Given this list of marker genes Cib1, Akirin2, Mvd, H2ac13, Foxj2, Clec7a, Ifit3, Ifitm1, Map2k5, Rbbp9, Ern1, Bcl7a, Lilrb4a, Zp3, Tfap2e, Cd59b, Wnt2, Bcl2, Kifap3, Trpc5, Ambn, Has2, Bnipl, Nodal, Hif1a, Hsf1, Glmn, Inppl1, Fgf1, Ptpn22, Usp17le, Fbxw4, Abl1, Fxn, Dlx6, Cdk6, Tjp1, Ifi35, Pbxip1, Pla2g4a, Gata1, Eef1e1, Sult2b1, Pdgfrb, Setd1a, Prkd1 (NCBI Gene Id 18760), Trf, AY074887, Tmigd1, Sgpp2, Irak4 (NCBI Gene Id 77562), Kdf1, Foxa3 (NCBI Gene Id 15377), Pdpk1, Prkd2, Raf1, Ptprz1 (protein tyrosine phosphatase receptor type Z, polypeptide 1), Tfap2b, Azin1, Btla, Niban2, Zfp143, Zc3h12d, Dgcr8, Ceacam1, Irs2, Trpv2, Irgm1, Ripor2, Errfi1, Wdr62, Vav3, H2-M3, Dmd, Hmga2, Pdcd5-ps, Jund, Itga2, Il20rb, Grk5, Ptgdr2 (prostaglandin D2 receptor 2), Por, Cd109, Smad7, Eps15, Krt4, Reg2, Sts, Grk2, Atxn1, Sparc, Flt4, Acer2, Abcc8, S100a13, Sftpd, Scin, Avp, Sox18, P2ry6, Gata3, Dach1, Arhgap5, Aqp11, Septin4, Ptprn, Smarcb1, Dlc1, Junb, Itga1, Calcrl, Icosl, Celf1, Hdac5, Il1rl1, Nf2, Crlf1, Edn2, Rest, Areg, Irak1, Prl, Prdm1, Syk, Adm, Pim1, Fezf1, Nlrc3, Ogn, Fbrs, Braf, Cdkn2c, Rps6kb1, Vtcn1, Cthrc1, P3h3, Ppp1r15a, Camk2d, Rida, Foxg1, Emp2, Pramel7, Cep131, Slurp1, Smad2, Tns3, Col18a1, Gna12 (NCBI Gene Id 14673), Smo, Setd4, Ing4, Prrx2, Wnt7a, Taf6, Cxcr2, Ace (angiotensin I converting enzyme), Fermt2, Cblb, Sdcbp, Agbl4, Nudt6, St6gal1, Cdkn1b, Iqgap3, Adora3, Jun, Fntb, Lama5, Tfdp1, Lims2, Cxcr3, Ccdc117, Smarcd3, Meis3, Gab2, Smad3, Zfp580, Egf, Nupr2, Arrb2, Mta3, Myog, Ifit3b, Akt1, Optn (optineurin), Gnai2, Tnfsf9 (tumor necrosis factor (ligand) superfamily, member 9), A4gnt, Ctf2, Aif1, Pkhd1, Trim24, Rab25, Bricd5, Kctd11, Tgfb1, Cd46, Cdc6, Pdcd4, Il3, Il11ra2, Atoh8, Sulf2, Adam17, Chp2, Sfrp4, Ppp2r3d, Ccne1, Ifnb1, Znhit1, Cldn3, Akr1b1, Cfdp1, Agtr1b, Comt, Ddx39b, Pik3ca, Cela1, Lyn, Tarm1, Vegfc, Osr1, Cdca7l (NCBI Gene Id 217946), Nme2, Hyal1, Erbb3, Gnrhr, Mapk14, Ccn2, Fgf6, Wfdc1, Bmpr2, S1pr1, Wnk2, Gas1, Esr1, Wwtr1, Scrib, Il33, Il31ra, Prkar1a, Tnf, Phox2b, Spn, Ccna2, Cacul1, Zfp503, Pds5b, Fto, Npr3, Ccnd1, Zbtb17, Cdkn2b, E2f4, Tmem119, Fzd3, Vsx2, Pou1f1, Lin28a, Rspo1, Emc10, Zfp36l1 (zinc finger protein 36, C3H type-like 1), Rassf5, Dkc1, B4galt7, Ahr, Klf4, Eng, Prrx1, Tsc22d1, Pmaip1, Adcyap1, Tial1, Rsu1, Kcnk2, Pax6, Dot1l, Foxj1, Vsig4, Carmil2, Riox2 (NCBI Gene Id 78649), Pten, Marcksl1, Rassf10, Drd4, Orc1, Bcar3, Tpd52, Rprd1b, Srf, Nkx2-5, Apobec1, Egfr, Nr2f2, Id4, Hoxd13, Rnf139, Foxp3, Adam33, Nap1l1, Dsc1, Gli3, Topors, Dmrta2, Pde5a, Mapk8, Blm, Ifng, Hnf4a, Bmp7, Dspp, Klf11, Xrcc6, Vax1, Fezf2, H19, Ptn, Txnl4b, Sfrp1, Myo16, Serpine1, Mir145a, Dvl2, Ccn5, Pla2g2a, Trim71, Fut2, Six4, Ada, Adam10, Zbtb7b, Reg1, Tbx18, Ntrk3, Hpgd, Klf5, Vsir, Nr3c2, Ptpn2, Nme1, Igfbp3, Trappc14, Med31, Fut1, Htra1, Hlx, Gdf9, Inha, Tnfrsf1b, Fndc3b, Cd44, Dbh, Bmi1, Ptgir, Fasl, Mir133a-1, Cdk1, Bmyc, B4galt1, Fgf17, Anp32b, Igf1r, Rc3h1, Fmc1, Ago3, Uts2r, Ecm1, Map3k5, Cd37, Tbx3, Adk, Grn, Plcd1, Zeb1, Actl6a, Fbln1, Akirin1, Timp1, Kitl, Il2, Pde1a, Spint2, Hmgn5, Sbno1, Nr5a2, Ifna11, Maged1, Pmp22, Cul4a, Nupr1, Atg101, Taf4b, Stat4, Osmr, Hspa1a, Tbrg1, Il7r, Gas6, Il4i1, Vegfa, Atg13, Cyp1b1, Prl2c3, Gpc3, Lrrc32, Nfkbia, Cst3, Smarca1, N4bp2l2, Tac1, Lta, Fermt1, Fer, Slit2, Tyk2, Nkx3-1, Rps4x, Npm1, Cebpb, Rxfp2, Notch2, Cdc7, Gstp1, Osm, Hrh3, Ufl1, Hilpda, Cd209e, Ptpn1, Gdf5, Ghsr, Nfatc2, Lrrk2, Ftmt, Fas, Prkci, Rbm38, Zmiz1, Sox11, Tgfb3, Zfp335, Cnn2, Il1b, Creb1, Pkn1, Sirt1, Gna13, Prc1, Gid8, Gfap, Pkd2, Havcr2, Wdr13, Zfp703, Skap2, Tal1, Sos2, Klf9 (NCBI Gene Id 70273), Siglecg, Zbtb49, Megf10, Rasa1, Tesl1, Notch1, Cherp, Anxa2, Mapk1, Mdm4, Il10, Hmox1, Ndrg4, Pdgfd, Il21, Rgn, Cdon, Pbrm1, Fn1, Rps6ka2, Ndfip1, Adora1, Fanca, Nos3, Thrb, Cd244a, Ift80, Tmem127, Eif2ak1, Mir223, Fgf22, Trnp1, Ndufaf4, Pax3, Src, Pde4d, Btn2a2, Cnot6l, Ripply3, Neu1, Rasip1, Hmx2, Lef1, Il1a, Nck2, Fgf3, Drd2, Mir133a-2, Dnaja3, Tgfb2, Gja1, Marchf7 (membrane associated ring-CH-type finger 7), Sp1, Ski, Ier5, Esrp2, Chrd, Cd209c, Strn, Msx2, Sh3bp4, Hras, Nmbr, Mad1l1, Gpnmb, Mup20, Akr1c18, Eaf2, Rxra, Dhcr24, Wwc2, Dusp10, Pttg1, Slfn3, Bmp2, Ido1, Garem1, Ngfr, Odc1, Casp3, Fbln5 (NCBI Gene Id 23876), Ccl12, Il12rb1, Romo1, Avpr1b, Kank2, Cd209d, Zap70, Mks1, Traf5, Adarb1, Amelx, Ldlrap1, Nck1, Tnc, Intu, Pggt1b, Klb, Spdya, Sphk1, Tfap4, Il6, Sdc4, Sema5a, Mef2d, Avpr2 (NCBI Gene Id 12000), Klhl41, Gata6, Foxf1, Wdr6, Cd40lg, Pold4, Il12rb2, Wnt1, Vegfd, Cd22, Magi2, Krit1, Chst11, Gnas, Fosl2, Kiss1, Pdcd2, Ccn6, Laptm5, Gper1, Ihh, Tirap, Zbtb16, Skp2, Tesc, Ptk2b, Il5, Osgin1, Ndrg1, Cend1, Ccn3, Nolc1, Pdgfc, Itgal, Wdr48, Trp53inp1, Il2ra, Tnfrsf21, Ctla4, Jag1, Gucy2c, Becn1, Kit, Mir219a-2 (microRNA 219a-2), Reg3a, Gdf2, Kdm2b, Phf7, Tead1, Nos1, Glul, Ticam1, Ezh2, Sh2b3, Ss18, Pth1r, Peli1, Crtam, Fgf15, Clcf1, Rictor, Mstn (NCBI Gene Id 17700), Muc16, Sox2, Nog, Fgfr1, Six5, Insr, Tgm2, Il6ra, Marveld3, Ptprm, Aldh3a1, Tnfsf4, Csk, Shc1, Fgf21, Tfap2d (NCBI Gene Id 226896), Sf1, Pitx3, Slc7a5, Pin1, Ksr1, Vcam1, Cd1d2, Axin2 (NCBI Gene Id 12006), Grpr, Cer1, Ednrb, Acvrl1, Emilin1, Slc4a1, Six1, Kcnh1, Sinhcaf, Plag1, Bmpr1a, Prdx3, Gal, Cripto, Rtn4, Mir574 (microRNA 574), Lgmn, Gpr183, Jak3, Dhps, Shoc2, Gak, Ins1, Bst1, Smarcd1, Fzd9, Bex1, Chek1, Shcbp1, Trim32, Kif20b, C3ar1, Cnot8, Crh, Dpp4, Eppk1, Cd59a, Ang6, Pdcd5, Vash2, Gpld1, Il4, Isl1, Ngf, Cyp7b1, Mir205, Rasgrf1, Fadd, Snhg15, Ikzf3, Hmga1b, Smad6, Efnb1, Gata4, Sox10, Cd55, Dnajb2, Cnn1, Atp5if1, Pdgfb, Etv5, Kmt2a, Comp, Coro1a (NCBI Gene Id 16902), Ang, Mab21l2, Fxyd2, Chrnb2, Srpx, Pycard, Dis3l2, Oog1 (NCBI Gene Id 193322), Fes, Xcl1, Prkaca, Cdk2 (NCBI Gene Id 353061), Il12b, Pou3f2, Phlda2, Cops9, Mst1, Igfbp5, Ptprc, Ctnnb1, Slc25a27, Jcad, Slc16a2, Nox4, Dnmt1, Pth, Bmp4, Bicra, Map2k1, Flcn, Ppargc1a, Hes5, Tbx2, Enpp3, Pf4, Fnip1, Nampt, Ptgis, Cep43, Gkn3, Tsc1, Mdk, Mfn2, Cdkn2a, Ednra, Hoxa5, Esr2, Ndufs4, Cldn1, Carm1, Tlr9, Fktn, Dhx9 (NCBI Gene Id 98320), Gstp2, Ncam1, Twist1, Nr1d1, Tspo, Gpbar1, Atf5, Slc25a33, Il13, Gcnt2, Serpinf1, Nr2e1, Inhba, Shc4, Tnfsf13, Cnbp, Tcf3, Mbd2, Mmrn2, Ilk, Kdm5b, Bex4, Phip, Emd, Fgfr3, Mpl, Aimp1, Stat1, Rb1cc1, Epha1, Kras, Ptprj, Ereg, Itgb1bp1, Apc (NCBI Gene Id 11789), Clec2i, Rhoa, Lamc2, Bax, Zbtb7c, Timp2, Rarg, Emilin2, Plk5 (NCBI Gene Id 216166), Cd86, Rac2, Hp1bp3 (NCBI Gene Id 15441), Stat6, Twsg1 (twisted gastrulation BMP signaling modulator 1), Cd209a, Nell1, Pygo2, Cxcl10, Stat5a, Timp3, Atp5f1a, Bak1, Wdr77, Nod2, Muc2, Nr4a1, Il4ra, Pdgfra, Efnb2, Ackr3, Lmna, Aqp1, Tbx20 (T-box 20), Ryk, Nppc, Cldn19, Nacc2, Sox15, Selenok, Per2, Tnmd, Ddrgk1, Recql4, Rian, Mir1a-2, Vash1, Apela, Ift172, Fgf23, Med25, Il7, Cxcl12, Inca1, Egr1, Mir320, Ptpru, Mef2c, Ntn1, Pax7, Tiam1, Pdx1, Pitx2, Cd55b, Cdkn2d, Sfn, Ctsh, Map3k3, Uts2, Lig4, Nfatc1, Smim22, Otp, Zfp36, Dab2, Ifitm3, Msx1, Ggnbp2, Jaml, Crp, Eapp, Bcl2l1, Cdkn1c, Cckbr, Nrk (Nik related kinase), Nmi, Pla2g2f, Trim35, Nacc1, Ccr5, Bcl7b, Prkaa1, Gsk3b, Xirp1, Tfap2c, Runx3 (NCBI Gene Id 56483), Ascl2, Stat2, Gtpbp4, Ager, Fap, Rps6-ps4, Fbxo5, Zmpste24, Tgfbr1, Fgf16 (fibroblast growth factor 16), Csf3, Prdm4, Ctcf, Ash2l, Ang2, Il23r, Vegfb, Calr, Xbp1, Cdc20, Fam98a, Mmp2, Tie1 (tyrosine kinase with immunoglobulin-like and EGF-like domains 1), Pdcl3, Foxp1, Cav3, Hmgb2, Aggf1, Parp10, Mtss1, Disc1, Srsf6, Adipoq, Maz, Ptpn14, Tinf2, Cd276 (NCBI Gene Id 266672), Cx3cl1, Npr1, Fgf4, Sox8, Prkca, Ovol2, Ncor1, Pdcd6, Pbx1, Thbs4, Cd47, Minar1, Phb2, Cd274, App, Pawr (PRKC, apoptosis, WT1, regulator), Cadm4, Kiss1r, Stk4, Cnot7, Extl3, Bcl6b, Zfp423, Ppp3ca, Ssbp3, Lrp6, Prok1, Atxn1l, E2f7, Bcl6, Kmt2d, Tbx5, Hes1, Pou3f3, Rpa1, Tgif1, Ccl11, Vipr2, Retn, Mif (macrophage migration inhibitory factor (glycosylation-inhibiting factor)), Cd320, Ephb1, Tff1, Ccl26, Brd9, Ift57, Stat5b, Ripk3, Nmb, Ccn4, Csf2rb, Rnf10, Btk, Hdac4, Cpeb1, Rnf41, Fgf7, Zfas1, Slc6a4, Gnrh1, Oog2, Cdh1, Kat2b, St18, Ghrhr, Dlg1, Cd248, Reg3b, Cflar, Fabp4, Dppa2, Trp73, Derl2, Ctnnbip1, Hcls1, Appl2, Il12a, Spry1, Itgb3, Srpk2, Agtpbp1, Nos2, Agt, Pdf (peptide deformylase (mitochondrial)), Scn5a, Ovol1, Plcd3, Ghrl, Ighd, Csf2ra, Myb, Mustn1, Slc25a5, Rgs5, Mdm2, Mmp7, Ntf3, Wnt11, Rtkn2, Cd200, Fnta, Atp7a, Mir219a-1, Clu, Fnip2, Pax2, Pla2g2d, Igfbp2, Rbpms2, Sqle, Ascl1, Lrp5, Fth1, Malat1 (metastasis associated lung adenocarcinoma transcript 1 (non-coding RNA)), Gpx1, Serpinf2, Brk1, Tff2, C5ar1, Foxo3, H2-Aa, Ltf, Tnfsf13b, Bicral, Gata2 (GATA binding protein 2), Ephb2, Traf6, Cbfa2t3, Scx, Ccpg1, Dynap, Ocstamp, Mir24-2, Twist2, Dhcr7, Gnai3, Pparg, Actb, Sfrp5, Gkn1, Fzr1, Kdm1a, Ripk2, Rarb, Hmgcr, Cited2, S100a11, Hand2, Fgf20 (fibroblast growth factor 20), Ace2, Hmgb1, Slc35f6, Drd3, Hdac2, Agap2, Nlgn2, Clec11a, Sox17, Nkx2-3 (NK2 homeobox 3), Dct, Pkp2, Stx3 (NCBI Gene Id 20908), Bdnf, Arg1, Alox5, Cntfr, Rln1, Brip1, Rnf126, Ccl5, Bmpr1b, Pla2g5, Etv3, Rhbdd1, Trp53, Pdgfa, Bcl11b, Prkg1, Alox12, Rasal3, Hdac1, Clec4g, Cdh5, Ecrg4, Pid1, Tgfbr2, Vgll4, Hbegf, Itgb3bp, Nkx2-6, Thbs1, Lhx2, E2f1, Rbm10, Arnt2, Nppb, Xdh, Smarca4, Vhl, Ppp2r5c, Cd28, Ltk, Gdnf, Cdh3, Tcf7, Tnfrsf14, Gjb6, P3h2, Tacstd2, Il27, Folr2, Nras, Ppp1r16b, Tox, Esrra, Edn3, Hoxa3, Pim2, Egr3, Ift52, Rreb1, Bmp5, Cd300a, Adora2b, Ddx20, Gpr37l1, Tspyl5, Rapgef1, Cldn7, Stx4a, Il13ra2, Crlf2, Jak2, Bdkrb2, Ift74, Abcc4, Enpp2, Scg2, Slfn1, Cd1d1, Nrg1, Stat3, Ptprv, Tbx1, Npy, Kcna5, Txnip, Ptgfr, Tspan32, Nkx2-9, Vdr, Ctc1, Hrg, Mecp2, Bche, Dlec1, Phf14, Fgf5, Meis1, Il5ra, Pgf, H2-DMb2, Wnt7b, Etv4, Nqo2, Tipin, Mas1, Fgf10, Ptk2, Il11, Myd88, Anxa1, Csf1, S100b, Fgfr4, Prlr (prolactin receptor), Saal1, Cnmd, Efemp2, Ing5, Rapgef2, Cd3e, Stk11, Kat7, Shank2, Cxcl1, Xrcc5, Ptgds, Pla2g1b, Itgax, Scube2 (NCBI Gene Id 74421), Ell3, Cask, Pdcd1lg2, Serpinb7, Mcc, Crip2, Reg3d, Park7 (Parkinson disease (autosomal recessive, early onset) 7), Ptpn6, Fcgr2b, Dab2ip, Inpp5d, Mydgf, Foxp2, Aldh1a2, Cdc25a, Prkcq, Uhrf1, Casr (NCBI Gene Id 12374), Ndrg2, Ctnna1, Insm1, Nfib, T, Aplnr, Trpm4, Ptger4, Wnt3a, Sapcd2, Btg1, Rad51b, Vim, Glce, Runx2, Rela, Ddah1 (dimethylarginine dimethylaminohydrolase 1), Sash3, Ccl24, Cbx8, Ccnb1 (cyclin B1), Ikbkb, E2f3, Tafa5, Ntrk2, Rps9, Ptges, Tmem196, Ccr7, Cox17, Nherf1, Tnfrsf4, Kdr, Cers2, Flna, Nfe2, Crkl, H2-DMb1, Podn, Flt3l, Tek, Ptprf, Pml, Gli2, Gng5, Alox8, Edn1, F2r, Fgfr2, Pdcd10, Il18, Wnt9a, Tpbg, Birc7, Neurl1a, Lgals9, Wt1, Tgm1, Prox1, Hnrnpu, Skor2 (SKI family transcriptional corepressor 2), Igf1, Fam98b, Cacnb4, Dynapl1, Hspa1b, Mapk11, Tescl, Tfap2a, Map3k7, Gabbr1, Wnt10b, Irf1, Lefty1, Men1, Hpse, Acvr1c, Gjc2, Fbxo4 (F-box protein 4), Acer3, Erdr1, Foxo4, Reg3g, Birc5, Sos1, Cops8, Mn1, Btg2, Ang5, Actl6b, Plxnb3 (plexin B3), Apoe, Tmem131l, Fgfbp1, Epcam, Ccnd3, Csf2 (NCBI Gene Id 12981), Prkra, Ltbp3, Myc, S1pr2 (sphingosine-1-phosphate receptor 2), Elane, Ar, Glp1r, Lepr, Hmga1, Nrarp, Tnn, Selenon, Rbp4, Tnfsf18, Deaf1, Tyrobp, Flt1, Tnfrsf13b, Nup62, Bmp6, Cnot6, Cck, Gm128, Rpa3, Mtor, Rptor, Sphk2, Jarid2, Sh3rf1, Ctsl, Cxcl9 (C-X-C motif chemokine ligand 9), Gpam, Pex2, Slc4a2, Ccar1, Cxadr, Col4a3, Cd40, Pnp, Serpinb5, Epor, Smarcc1, Pthlh, Asph, Ghr, Atm, Lbh, Sox4, Cdk4, Shmt2, Lims1, Ptch1, Tax1bp3, Ddr2, Ccr2, Apln, Cyba, Trp63, Mmp9, Runx1, Dll4, Yap1, Spta1 (NCBI Gene Id 98361), Lgals3, Ptprk (protein tyrosine phosphatase receptor type K), F2, Tent5b, Lrp2, Terc, Tpm1, Stk3, Ghrh, Cip2a (NCBI Gene Id 224171), Dpt, Fancl, Tsg101, Igf2, Plcg1, Cysltr1, Id2, Prmt1, Ins2, Rbpj, Tbx19, Ccdc88a, Akt3 (NCBI Gene Id 98462), Dll1, Arg2, Ighm, Egln3, Iapp, Ift122, Spint1, Efemp1, Fuz, Cdc42, Tesl2 (NCBI Gene Id 245376), Ankrd2 (ankyrin repeat domain 2), Suz12, Mir744 (NCBI Gene Id 791070), H2-T23, Nr2e3, Gpr15lg, Esm1, Slc7a1, Myod1, Sav1, Cdc73, Pik3cd, Ppp1cc, Morc3, Cldn5, Prnp, Mab21l1, Gdf11, Mecom, Prkch, Bmp10, Dusp1, Fzd5, Flt3, Ift88, Lrg1, Paxbp1, Lhx5, Fzd7, Lgr5 (leucine rich repeat containing G protein coupled receptor 5), Scgb1a1, Cx3cr1, Rgcc, Ambra1, Dysf, Thpo, Mlxipl, Sod2 (NCBI Gene Id 20656), Foxe3, Cntf, Ets1, Avpr1a, Aspm, Oog3, Frzb, Erbb4, Itpr1, Pde9a, Crnn, Hipk1, Hck (NCBI Gene Id 99093), Csnk2a1, Ang4, Tmigd3, Dlg5, Pdpn, Nr4a3, Creb3, Mtbp (Mdm2, transformed 3T3 cell double minute p53 binding protein), Tshr, Kif3a, Bcl7c, Hey1, Cdkn1a, Pgr, Epo (NCBI Gene Id 13856), Smad1, Eif2ak2 (eukaryotic translation initiation factor 2-alpha kinase 2), Cd24a (NCBI Gene Id 12484), Cdca7, Slc39a10, Rnaseh2b, Adora2a, Osr2, Ceacam2, Synj2bp, Tslp, Nr3c1, Grem1, Ptgs2, Slamf1, Bex6, Ulk1, Rerg, Sirt6, Rps15a, Trib1, Bad, Socs1, Esrp1, Ddr1, Fbxo2, Lmo1, Sox7, Fgf18, Angpt1, Hipk2, Plac8, St8sia1, Pura, Tacr1, Csf2rb2, Apod, Card11, Ntrk1, Hmgn1, Plau, Cd81, Hey2, Six3, Mir24-1, Kcnn4, Foxm1, Itgb1, Tafa1, Bap1, Arx, Epha4, F3, Prdx4, Nes, Cth, Atf2, Mir143, Serpine2, Tnfrsf13c, Fgfrl1, Jup, Cav2, Btc, Cdh13, Fa2h, Tnfrsf9, Robo1, Chd5, Syf2, Vip, S2bpcox16 (synaptojanin 2 binding protein Cox16 readthrough), Lilrb4b, Meis2, Zfpm2 (NCBI Gene Id 320725), Rps3, Atad5, Bid, Itga4, Nox1, Alk, Nccrp1, Six2, Gli1, Irf6, Tnfaip3, Atf3, Htr1b, Irs1 (NCBI Gene Id 16367), Rnf187, Egfl7, Agtr2, Camp, Mycn, Afdn, Cdx2, Notch3, Tgfbr3, Phb1, Slit3, Ccl19, Disp3, Agtr1a, Brca2 (NCBI Gene Id 12190), Prkdc, Odam, Mitf, Tsc2, Ptafr, Ccnd2, Ier3ip1, Hpgds, Gnaq, Tgfa, Shox2, Idh2, Aimp2, Eid2, Spry2, Jag2, Sulf1, Tes, Cysltr2, Ccdc88b, Ptgs1, Csf1r, Med1, Pak1, Htr2a, Itch (itchy, E3 ubiquitin protein ligase), Il24, Fgf2, Mnat1, Ppard, Lzts2, Ifi30, Mmp12, Tcf7l2, Fgf9, Cpb2, Prkcz, Dlk1, Trem2, Mapk15, Btnl2, Lep, Ptger2, Prg4, Mafg, Smad4, Vstm2a, Lif, Icmt, Dyrk1a (NCBI Gene Id 76465), Foxo1, Xrcc4, Sat1 (spermidine/spermine N1-acetyl transferase 1), Rara, Cd4, Hhex, Nckap1l, Pemt, Mapk3 (NCBI Gene Id 26417), Tob1, Rb1, Bambi, Nf1, Epgn, Erbb2, Gkn2, Hspg2, Snai2, Sall1 (NCBI Gene Id 58198), Lbx1, Nbn, Il11ra1, Ccn1, Fgf8, Sirt2, Tns2, Ptbp2, Myocd, B2m, Wwc1, Rps6, Bnc1, Zfp609, Kif14, Clmn, Cdh2 (NCBI Gene Id 12558), Ncoa3, Spin4, Kmt2c, Rap1gap, Slc7a11, Mapk8ip1, Dlx5, Plxnb1, Hpn, Lst1, Sfrp2, Id1, Bloc1s2, Rpl23, Slfn2, Tmem250, Cyp27b1, Emx1, Il34, Il15, Cd9, Prl2c2, Apoh (apolipoprotein H), Sox9, Nanog, Birc6, Cd80, Pik3r1, Htr2b, Adamts1, Gsdme, Slc39a9, Tlr2, Enpp7, Lifr, Smpd3, Tert, Ccl2, 4930503L19Rik, Klf13, Mzb1, Shh, Tfrc, Npy5r, Arid2, Cd6, C1ql4, Eya1, Adrb2, Il6st, Kdm4c, Jtb, Il23a, Gnl3 (guanine nucleotide binding protein nucleolar 3), Pramel1, Rogdi, Smyd2, Frs2, Cxcl11, Ccr3, Cd74, Dicer1, Tlr4, Hdac6, Dusp22, Cebpa, Atraid, Brpf1, Arrb1, Cd38, Meak7, Tlx1, Bok, Zfp777, Fosl1, Insl3, Wnt5a, Stxbp4, Hpse2, Pias1, Smarca2, Adgrg1, Itgav (NCBI Gene Id 76358), Cav1, Mir702, here is a description of the gene set: Mouse Gene Set: GOBP_REGULATION_OF_CELL_POPULATION_PROLIFERATION Any process that modulates the frequency, rate or extent of cell proliferation. studied in species Mus musculus